Given this list of marker genes Reln, Fgfr1, Fbxo45, Lhx6, Slit2, Arx, Robo1, here is a description of the gene set: The migration of cells in the cerebral cortex in which cells move orthogonally to the direction of radial migration and do not use radial glial cell processes as substrates for migration. Mouse Gene Set: GOBP_CEREBRAL_CORTEX_TANGENTIAL_MIGRATION species: Mus musculus